The following is a description of a gene set: MAPK1/MAPK3 signaling species: Homo sapiens Human Gene Set: REACTOME_MAPK1_MAPK3_SIGNALING, and this is the list of marker genes: ICMT, MAP2K2, SPRED1, PSMA1, LAMTOR2, FNTB, DUSP16, PPP2R5A, RANBP9, FGFR1, USP17L2, GRIN1, LRRC7, SRC, UBC, IL6R, FLT3LG, PSMD14, IL2RG, PSMA3, ARL2, BCL2L1 (BCL2 like 1), PTPRA, FGF19, GDNF, PSMB6, CSF2RB, RAPGEF2, DUSP2, PSMA5, NRG2 (NCBI Gene Id 9542), CAMK2B, NCAM1, FGA, FGF8, FGF18, LYPLA1, PHB1, KBTBD7, SPTBN1, GRIN2B, SYNGAP1, PSMD1, CNKSR1, KSR1, PDGFA, PEBP1, ARRB1, ARTN, RBX1, NRG4, PTPN11, IRS2, FNTA, VCL, RASA3, GRIN2D, PRKG2, RGL1, EPGN, JAK2, IRS1, FRS2, PPP2R1A, PIK3CA, PSMD11, PSMC2, SPTBN2, PSMD12, ITGB3, RCE1, PDGFB, GFRA4, DLG2, KITLG, MARK3, PSMC3 (NCBI Gene Id 96121), RASAL1, JAK1, SOS1, PPP2R5C, IQGAP1, RGL3, ADRM1, KRAS, JAK3, DLG1, CNKSR2, RASA1, BRAP, IL6, PSMD3, CSK, FGF20 (NCBI Gene Id 26281), CALM1, IL3RA, PSMC6, RASAL2, NRAS, ERBB2, VWF, DUSP6, KSR2, ANGPT1, PIK3R2, PSMB2, PDE6D, PSMD8, PSMA6, CAMK2D, ARAF, ABHD17A (abhydrolase domain containing 17A, depalmitoylase, NCBI Gene Id 81926), RET, PSMC1, FGF6, FGF1, MAPK3, MAPK1, RASA4 (NCBI Gene Id 10156), PSMD6, PPP2CB, RPS27A, DLG4, FGF23, DUSP5, PSMC4, ITGA2B, ACTB (actin beta), YWHAB, KLB, NRG1, PSPN, SHC2, SHC1, RASGRF1, PDGFRB, EGF, SPTA1, FGF22, MAP2K1, BTC, KIT, DUSP1, SPRED2 (sprouty related EVH1 domain containing 2), FN1, RASA2, BRAF, PPP1CC, EGFR, PSMB5, MRAS, CSF2RA (NCBI Gene Id 8282), TEK, MAP3K11, RGL2, FYN, GRB2, DUSP9 (NCBI Gene Id 1852), PSMA4, ERBB3, APBB1IP, PTK2, CAMK2G, SPTBN5, PSMB1, FGG, RASGRP4, LAT, SPTBN4, HGF, RASGRF2, CSF2, HRAS, IL6ST, AREG, PPP2R5E, FGF5, PPP2R5B (protein phosphatase 2 regulatory subunit B'beta), NEFL, IL2RB, PTPN7, ABHD17B, PSMB7, RASAL3, FGF17, FGFR4, FGFR2, GFRA1, PTPN3, FGF10, IL2RA, PPP2R5D, UBB, DAB2IP, ZDHHC9, UBA52, FGF4, GFRA3, PSMD2 (NCBI Gene Id 5708), IL2, CDK1, EREG, FGFR3, IL17RD, SPRED3, ACTG1, FGF9, PEA15, PPP5C, SPTAN1, PSMD7, TLN1 (NCBI Gene Id 7094), NRTN, PDGFRA, FRS3, LAMTOR3, ERBB4, NRG3, ACTN2 (actinin alpha 2), FGF7, TGFA, DUSP10, FGF2, DUSP7, RASGRP1, PPP2R1B, MET, PSMA7, RAP1B, FGF3, SHOC2, FGF16, CAMK2A, CUL3, PSMA2, NF1, DUSP4, TYK2 (tyrosine kinase 2), PSMD13, PIK3R1, SEM1, PPP1CB, PIK3CB, ARRB2, KL, RASGRP3, PAQR3, SHC3, PSMB4, RALGDS, RASGEF1A, GOLGA7, FLT3 (NCBI Gene Id 2322), ABHD17C, DLG3, IL5, RAP1A, IL3, MAPK12 (mitogen-activated protein kinase 12), PSMC5, GFRA2 (GDNF family receptor alpha 2), WDR83, PPP2CA, PRKCQ, RAF1, HBEGF, FGB, IL5RA, PSMB3, SPTB, DUSP8